The following is a description of a gene set: Any process that activates or increases the frequency, rate or extent of the chemical reactions and pathways resulting in the formation of phospholipids. species: Homo sapiens Human Gene Set: GOBP_POSITIVE_REGULATION_OF_PHOSPHOLIPID_BIOSYNTHETIC_PROCESS, and this is the list of marker genes: FABP3, HTR2B, CHP1, HTR2C, CAPN2, ACSL3, ADGRF5, NR1H4, XBP1, RAB38, HTR2A